The following is a description of a gene set: Mouse Gene Set: MIR_184_3P species: Mus musculus Genes predicted to be targets of miRBase v22 microRNA mmu_miR_184_3p in miRDB v6.0 with MirTarget v4 prediction scores > 80 (high confidence targets). from publication Chen Y, Wang X (PMID 31504780), and this is the list of marker genes: Nus1, Epb41l5, Sidt2, Tectb, Ntan1, Nhlrc1, Spn, Ncor2, Prepl (prolyl endopeptidase-like)